Given this list of marker genes Pcdh15, Cnih1, Tmem202, Myt1l, Tbx10 (T-box 10), Fam149b, Ftmt, Utp18, Prkaa2, Cmpk1, Slc4a5, Col11a1, Prl7a2 (prolactin family 7, subfamily a, member 2), Skint7, Slc10a1, Syt4, Rad51, Slc5a3, Bbip1, Ppp1r3b, 9530002B09Rik, Nipsnap3a, Pcdh8, Syncrip, Atxn7, Myh10, Rhobtb1 (Rho-related BTB domain containing 1), Foxf2, Cav2, Spef2, Pcdh17, Tsku, Asb7, Isca1, Tmem243, Slfn4, Lrrc28 (leucine rich repeat containing 28), Ms4a4d, Kif3c, Wnk1, C1qtnf7, Lgals3, Gnao1, Caprin1, CK137956, Jmjd4, Trnt1, Kti12 (NCBI Gene Id 76297), Oosp2, here is a description of the gene set: Genes predicted to be targets of miRBase v22 microRNA mmu_miR_200c_5p in miRDB v6.0 with MirTarget v4 prediction scores > 80 (high confidence targets). from publication Chen Y, Wang X (PMID 31504780) species: Mus musculus Mouse Gene Set: MIR_200C_5P